The following is a description of a gene set: Any process that stops, prevents, or reduces the frequency, rate or extent of the phosphorylation of peptidyl-serine. Human Gene Set: GOBP_NEGATIVE_REGULATION_OF_PEPTIDYL_SERINE_PHOSPHORYLATION studied in species Homo sapiens, and this is the list of marker genes: NLRP2B, NT5DC2, CNKSR3, PAQR3, PTEN, RASSF2, DMTN, GADD45A